Given this list of marker genes IGF2R, PDXK, PI4K2A, S100A4, ANXA1, MMP19, TMT1B, CD84, SDSL, CSF1R, MRAS, VWA5A, EMP1, LILRA2, CYP1B1, LRP3, CD86, PTPN6, STARD8, SNAI3, PAPSS1, ZEB2, ANXA4, ANXA11, HMOX1 (heme oxygenase 1), PFKFB4, CD52, NIBAN2, CAPG, CYTH4, NEK6, RAI14, PLEKHO2, EVA1B, GSN, LGALS1, ME1, PLXDC2, VIPR1, GCLC, FGL2, CLDN23, FPR3, FLRT2, TYROBP, CPQ, CLEC5A, APOC1, RHOC, ABCG1, PKM, CYP27A1, IL1RN, MNDA, CAMK1, RNF130, SPP1, CST3, ANXA2, CCR1, DAB2, ZMIZ1, DAGLA, FUCA2, KCNE3, SPHK1 (NCBI Gene Id 8877), ALDH3B1, IGSF6, KIAA0930, ZNF366, CTSS, HEXB, CLEC4A, SLC31A1, FGR, PPM1M, SLC38A6, SLC7A8, GPNMB, FLVCR2, FABP4, IL17RA, CD63, SPINT1, PDE4A, EEF1AKMT3, CEBPB, NRROS, KIFC3, CAPN2, ANXA5, NLRC4, SLC35E4, CYFIP1, PNKD, SLC37A2, RNF122, EGR2, SLC17A5, FCGRT, SDCBP, NT5E, OTOA, CD36, NUMB, SERPINE1, HK3, IL3RA, LIMS1, HSD3B7, S100A10, MAPKAPK3, GLIPR1, CLIP2, TBXAS1, IGF2BP2, DHRS9, MFSD12, TPST1, PLBD1, FKBP1A, SIGLEC9, S100A11, DCSTAMP, CEBPA, CTSD, SCARB2, TPM4, GLUL, HTRA1, STAB1, C3AR1, GPC2, CLEC12A, ABCC3 (NCBI Gene Id 8714), HEBP1, CTSB (NCBI Gene Id 3896), MYOF, CYBB, C5AR1, G6PD, ATP6AP2, IFI30, PDLIM7, GREM1, IL1R2, CD300LB, PLIN2, AVPI1, ARAP3, SIPA1L2, PLA2G7, SLC1A3, CD300C, CAMSAP2, ARHGAP18, TSPO, SLC27A3, RGCC, TKTL1, ADAP2, LTBR, RASSF4, CXCL16, APOE, ATP6V1A, MMP9, VWF, SLC44A1, TIMP2, SLC26A11, NPC2, PTPRE, C1orf54, GLMP, LPL, LYZ, LMNA, SLC16A3, SH3BGRL3, GPR35, HCST, NCEH1, LGALS3, CARD9, TNFRSF21, MITF, SIRPA, SHTN1, SMCO4, VIM (vimentin), CD33, C3, PACSIN2, CD9, FOS, CHST13, RPS6KA1, TNS3, THEMIS2, FAM20C, NPL, CA2, CST6, PPARG, SLC49A3, MGST1, HAVCR2, GLIPR2, ICAM5, FBP1, ITGAX, GPC4, SLC31A2, FTL, TGFBI, CREG1, ALCAM, INF2, LHFPL2, S100A6, SPI1, CCR5, ZMYND15, RXRA, ALDH1A2, KCTD12, SLAMF8, TMBIM1, MPP1, LRP1 (NCBI Gene Id 4035), SRXN1, LINC00520, ITGAM, CORO1C, PTGS1, PIEZO1, PDGFRB, CD151, RGL1, ZYX, C5AR2, LINC01010, GLA, TMEM158, TM4SF19, KCNN4, ENG, SPRED1, AIF1, PTGR1, SLCO3A1, ASPHD1, ABCA1, SCG5, DPYSL2, here is a description of the gene set: from publication Fletcher HA, Keyser A, Bowmaker M, Sayles PC, Kaplan G, Hussey G, Hill AV, Hanekom WA (PMID 19239680) Human Gene Set: FLETCHER_PBMC_BCG_10W_INFANT_BCG_STIMULATED_VS_UNSTIMULATED_10W_DN Genes down-regulated in peripheral blood mononuclear cell stimulated vs unstimulated in infants (10w) after exposure to BCG (Danish strain BCG Statens Serum Institut, Denmark), time point 10W. Comment: PBMCs drawn at 10 weeks following immunization at birth species: Homo sapiens BACKGROUND: Novel tuberculosis (TB) vaccines recently tested in humans have been designed to boost immunity induced by the current vaccine, Mycobacterium bovis Bacille Calmette-Guerin (BCG). Because BCG vaccination is used extensively in infants, this population group is likely to be the first in which efficacy trials of new vaccines will be conducted. However, our understanding of the complexity of immunity to BCG in infants is inadequate, making interpretation of vaccine-induced immune responses difficult. METHODS: To better understand BCG-induced immunity, we performed gene expression profiling in five 10-week old infants routinely vaccinated with BCG at birth. RNA was extracted from 12 hour BCG-stimulated or purified protein derivative of tuberculin (PPD)-stimulated PBMC, isolated from neonatal blood collected 10 weeks after vaccination. RNA was hybridised to the Sentrix(R) HumanRef-8 Expression BeadChip (Illumina) to measure expression of > genes. RESULTS: We found that ex vivo stimulation of PBMC with PPD and BCG induced largely similar gene expression profiles, except that BCG induced greater macrophage activation. The peroxisome proliferator-activated receptor (PPAR) signaling pathway, including PPAR-gamma, involved in activation of the alternative, anti-inflammatory macrophage response was down-regulated following stimulation with both antigens. In contrast, up-regulation of genes associated with the classic, pro-inflammatory macrophage response was noted. Further analysis revealed a decrease in the expression of cell adhesion molecules (CAMs), including integrin alpha M (ITGAM), which is known to be important for entry of mycobacteria into the macrophage. Interestingly, more leukocyte genes were down-regulated than up-regulated. CONCLUSION: Our results suggest that a combination of suppressed and up-regulated genes may be key in determining development of protective immunity to TB induced by vaccination with BCG.